The following is a description of a gene set: Human Gene Set: GOBP_REGULATION_OF_ANTIFUNGAL_INNATE_IMMUNE_RESPONSE Any process that modulates the frequency, rate or extent of an antifungal innate immune response. species: Homo sapiens, and this is the list of marker genes: USP15, FAM3A, TRIM62, PLA2G5, SPI1